Given this list of marker genes SPACA4, PTCD1, FEZ2, STAT1, CHP1, LTO1, NFYC, LENG9, CA9, IGHMBP2, PPP2R1A, H2BC5, PANK4, SCRN3, FCGR2B, EHF, PRTG, SHC1 (SHC adaptor protein 1), PTGER3, SOCS1, ABCG4, RUSF1, NRROS, DDX5, TMEM130 (NCBI Gene Id 222865), USP7, RBFA, PCDHB12, IL15RA, HOXD3, DNAJB5, TBC1D13, ACSF2, NCOR1, ARFGAP3, CBFA2T2, FAM43A, USP6NL, BAP1, UVSSA, ACAP3, SPRED2, SLC66A1, TENM4, H2AB2, RNF112, UBALD2, PLEKHM3, FAM120C, SMC5, CHID1, PRKCD, COL4A5, SOX13, DUS1L, COL11A2, TMEM242, BTBD8, PALD1, PDCD1LG2, F13A1, KANSL3, SMURF2, PAPOLB, GRINA, ICOS, TRIM33, ATOH8, MTNAP1, TMEM161A, CCDC54, UBR5, DLL3, MTIF3, AGPAT4, PDXP, TTC38, RAB3IP, CAPN2, SERPINB6, EIF2AK1, CBLN3 (NCBI Gene Id 651052), FOLR1 (folate receptor alpha), THRSP, AMN, GBF1, ID2, SCNN1G, NRSN1, CAST, TRAM2, XYLT2, KCNG4, NDUFV1, SLC23A1, MAP2K6, TTLL11, GPR155, TMEM241, ENTPD6, FRMD4A, TMEM59L, LCP1, CRAT, SLC28A2, IMPACT, AK3, HS1BP3, AP1S2, MYADM, SLC25A40, TSR3, ARHGAP23, ZYX, TMEM129 (NCBI Gene Id 92305), ST8SIA2, CYP2F1, SORT1, ST8SIA5, TRAF3, GABPB1, PITX2, PLCG1, TRPV6, TMX3, GPR173, ARHGAP30, CPNE1, SMIM14, SMOC1, NEFH, RFX5, MRGPRE, ST14, ALKBH4, BOP1, AMELX, SLA2, B4GALNT2, PPARGC1B, AK4, MIB2, ACOT2, KDM7A, KIAA0753, BCL6, KRT2, ZNF777, GALNT3, SLC45A3 (NCBI Gene Id 85414), PEX16, PCLAF, RALGAPA1, POU4F2, SPRTN, TOM1, PAM, STRN3, RAB40B, MKNK2, RASL10A, EARS2, TRIP12, NAA60, ALDH18A1, C1orf52, TNS3, MOB3A, GAA, CIAO3, NDRG3, KANSL1L, GPAM, DDR2, KLC3, RBM42, RASGEF1B, CACUL1, IFT80, CX3CR1, HSD11B1, ARID5A, YTHDC1, PRLR, CKLF, HS6ST1, RIF1, CCDC117, NRDE2, ULK3, SUFU, CDC25B, TYK2, ZNF444, EZH1, FAM120B, HS3ST4, SNHG8, PPP1R8, IQSEC1, here is a description of the gene set: Human Gene Set: GSE20198_UNTREATED_VS_IFNA_TREATED_ACT_CD4_TCELL_UP studied in species Homo sapiens Genes up-regulated in the activated CD4 T cells (48h): control versus interferon alpha. from publication Filén S, Ylikoski E, Tripathi S, West A, Björkman M, Nyström J, Ahlfors H, Coffey E, Rao KV, Rasool O, Lahesmaa R (PMID 20304822) The aim of this study was to identify genes regulated by IL-12, IL-18 and IFN-alpha during early differentiation of human Th1 cells